Given this list of marker genes SCGN, CREBZF, ENDOU, LRRTM2, CYRIA, PRKD2, ANXA10, JAK2, NLRP1, CD27, MDM2, MUC7, ANKRD46, HLA-DMB, FAM76A, MED22, IFI16, TK1, PTHLH, CDC25A, SLC12A4, ADPRH, PAPSS2, ENSG00000291006, PDE4DIP, MARCHF2, IFIH1, PDE8A, LY9, PARM1, ZBTB1, VAMP3, IRF1, LAMA5, PIGA, PSMB8, PTK2B (NCBI Gene Id 5748), MAPK10, CAMK1G (calcium/calmodulin dependent protein kinase IG), CLEC2B, ATG5, NDUFB8, SPOCK2, HSPB1, PART1, COPS5, TRPC2, PRPH, ASGR2, CD84, BST1, NCAM2, PLCG1, DZIP3, UCN, DCT, KRT85, CDC42EP1, GRIN2B, ASGR1, ISG20, NELL1, PLD3, PHACTR2, PAM, FOXA1, POU2AF1, WIF1, SCN5A, UBE2J1, ID3, ARHGEF5, CYP2D6, FRZB, TCEAL4, HIF1A, PHTF1, SCGB1A1, KRTAP5-9, LRP4, ADAM18, BARX2, MTCL1 (microtubule crosslinking factor 1), LORICRIN, TUBB2B, TMOD1, INSL4, LSM6, PRIM1, CARD8, RBP1, DNAH3, GBP2, ALDOC, PADI2, BCAT2, CCDC28A, CYB561, AHDC1, GBX1, PTTG1, GABBR1, CDH13 (cadherin 13), POU2F2, USP11, XAF1 (NCBI Gene Id 54739), APOBEC3B, MOXD1, ECM1, TMEM106C, SLC27A2, RAB29 (RAB29, member RAS oncogene family), THRB, ERAP1, FMO5, MTCL2, CALCA, MDFIC, KRT20, FRMPD1, WFS1, ITGB7, CENPC, SUMO3, LCE2B, BTN2A1, RS1, VWA5A, N4BP2L2-IT2, UTF1 (undifferentiated embryonic cell transcription factor 1), ATP6V1C1, ST20, IL23A, CCND1, PLEKHB1, ADGRE5, NPR3, CD163, ITIH3, TRPV6, CRHR1, HMHB1, CST3, NDUFV2, PDK2, RAB11FIP5, USP24, MYO10, MAP3K10, HSPA1L, ANK2, NEDD4, ZFP69B, MSC, TRAPPC3, PIM2, IPCEF1, FOXJ1, UPK1B, COX20, LYST, DGCR6L, HNRNPA1 (heterogeneous nuclear ribonucleoprotein A1), APOM, CDC14B, AFF3, GTF2B, AP1S1, BSN, SERPINB2, PEX3, TGFB3, INPP5B, HSDL2, WFDC2, FBXL7, CCL2, ADH5, PRM1, DOLPP1, PLA2G1B, IFNA8, PGAP1, PHACTR1, CAPN9, ADCY6, RAD51C (RAD51 paralog C), GLI1, SERPINB8, ISG15, ESYT1, CBARP, FAP, SSTR5, BST2, EPHB2, ABO, GSTA2, here is a description of the gene set: studied in species Homo sapiens Genes up-regulated in CD4 T cells: untreated versus progesterone. from publication Lee JH, Ulrich B, Cho J, Park J, Kim CH (PMID 21768398) We examined the global gene expression pattern of T cells regulated by progesterone to gain further insights into the regulatory mechanisms of progesterone. We found 325-347 cord blood T cell genes up or down-regulated by P4 in the presence or absence of exogenous TGFb1. Peripheral blood T cells were relatively unresponsive with only 30-genes regulated by P4. IL-6 receptor (IL-6R) expression was greatly down-regulated by progesterone in cord blood, but not PB, T cells. Overall, these differences in gene expression are consistent with the differential responses of cord blood and peripheral blood T cells to progesterone. To gain insights into the differences of progesterone and control dendritic cells, we performed a microarray study and found ~genes regulated by progesterone in dendritic cells. The gene expression information suggests that progesterone has the potential to alter dendritic cell responses to cytokines, chemokine production, and migration which in combination would control T cell differentiation. Human Gene Set: GSE22025_UNTREATED_VS_PROGESTERONE_TREATED_CD4_TCELL_UP